Given this list of marker genes MGLL, ABHD16A, DGAT2L6, PLA2G4A, ABHD16B, ABHD12B, DGAT1, MOGAT3, AWAT2, FAAH, MOGAT2, DAGLA, ABHD6, DAGLB, ABHD12, DGAT2, here is a description of the gene set: species: Homo sapiens Human Gene Set: GOBP_MONOACYLGLYCEROL_METABOLIC_PROCESS The chemical reactions and pathways involving monoacylglycerol, any ester of glycerol in which any one of its hydroxyl groups has been acylated with a fatty acid, the other being non-esterified.